Given this list of marker genes Snrpb, Prpf4, Rpl37, Isg20l2, Dcp2, Gemin2, Cdk7, Prpf19, Apobec4, Psmd3, Csnk1e, Cactin, Lsm2, Skic3, Psmb1, Smg7, Rpl36, Rbm42, Hbs1l, Senp3, Zfp36l1, Rps3, Tnfsf13 (tumor necrosis factor (ligand) superfamily, member 13), Psmb3, Tcerg1 (NCBI Gene Id 76839), Psmb2, Pnn, Ptbp1 (NCBI Gene Id 19205), Exosc2, Rpl35rt, Edc4, Prpf40a (pre-mRNA processing factor 40A), Nup58 (NCBI Gene Id 71844), Tra2b, Upf2, Mettl14, Srsf8, Fau, C1d, Lsm1, Rps15a, Puf60, Rbm25, Zc3h18, Slbp, Utp15, Ik, Eif4a2, Prpf31, Pabpn1, Xrn1, Rbmx2, Pelp1, Snu13, Rps19, Polr2h, Ppp2ca, Rpl3, Sec13, Rbm8a, Eri1, Psma4, Cnot10, Sf3b4, Polr2k, Exosc1, Akt1, Rpl29, Cnot2, Rpl32, Bud31, Snrnp70, Nup85, Mettl3, Nup50, Utp4, Hnrnpk, Nxf1, Ppihl, Uba52rt, Htatsf1, Snip1, Nup205, Ubl5, Rps10, Hspa1a, Polr2g, Rplp0, Gtf2f2, Sarnp, Rps5, Rrp36, Ppil2, Cstf2t, Wdr70, Dhx15, Ythdc2, Las1l, Tex10, Ddx42, Nup88, Rbmx, Rpl12, Rps4x, Ebna1bp2, Gemin4, Rps27rt, Sf3a3, Sf3b1, Psma6, Psmd12, Dcaf13, Snrnp25, Nob1, Imp3, Acin1, Snrnp48, Rbm26, Ubc, Rpl36a-ps1, Isy1, Tgs1, Zcchc8, Paip1, Hnrnpa1, Utp14a, Rpl13a, Wdr33 (WD repeat domain 33), Rpl36al, Ctnnbl1, Snrpc, Plrg1 (NCBI Gene Id 99527), Rpl36a, Cwc25, Eif4e, Rps14, Psmd7, Rcl1, Prpf8, Exosc10, Rbm27, Luc7l3 (NCBI Gene Id 67684), Riok2, Ndc1, Magoh, Cnot1, Hnrnpa3, Polr2d, Rpp14, Cdc40, Rpl18 (NCBI Gene Id 19899), Hnrnpl, Smg8, Rnmt, Wdr75, Nup155, Rpl27, Ppp2r2a, Srsf3, Smndc1, Sympk, Cnot9, Zc3h3, Fyttd1, Snrpe, Cstf1, Cnot11, Hnrnpr, Lsm4, Tnks1bp1, Tsr1, Clp1, Rpl4, Hnrnph2, Nsrp1, Skic8, Ubb, Srrm2, Wdr82, Smg9, Rpl21 (ribosomal protein L21), Rpl27a, Syf2, U2af2, Adar, Prcc, Heatr1, Dhx35, Ythdc1, Psmc2, Gemin5, Rps15 (NCBI Gene Id 20054), Psmc5, Adrm1, Ranbp2, Gemin7, Prkrip1, Utp25, Dcp1a, Polr2l, Tbl3, Hnrnpc, Rbm17, Chtop, Rps27l, Gtf2h5, Rps27, Rps25, Nxf7, Rpl17, Smg6, Khsrp, Papolg, Rps8, Prpf3, Nip7, Ncbp1 (nuclear cap binding protein subunit 1), Sf3b3, Srsf5, Thoc3, Ywhaz, Seh1l, Srsf10, Rpl10l, Rps3a1, Rpl22, Ddx6, Ppih, Rps26, Gtf2h2, Pabpc1, Wbp4, Exosc6, Psmc4, Cpsf2, Zrsr2, Dcp1b, Rps27a, Rpl13, Polr2e, Rps29, Wdr36, Papola, Bms1, Rps28, Fus, Xpo1, Lsm11, Hspb1, Smg1, Fam32a, Ywhab (tyrosine 3-monooxygenase/tryptophan 5-monooxygenase activation protein, beta polypeptide), Cnot4, Cnot7, Hnrnpf, Lsm3, Cherp, Polr2b, Cstf2, Snrpn, Clns1a, Wdr18, Rps17, Wdr77, Mfap1a (NCBI Gene Id 67532), Edc3, Mapkapk2, Sf3b5, Pcf11, Mnat1, Polr2f, Gtf2f1, Mphosph6, Rpl34, Nop14, Apobec2, Rpl6, Snrpd3, Gspt2, Rpl10, Rpl19, Snrnp27, Dhx16, Eif4a3, Yju2, Mphosph10, Pnrc2, Rpl26, Rbm39, Anp32a, Sf3a1, Ddx47, Rpl39, Cwc27, Thoc7, Tpr, Zfc3h1, Prpf4b, Smu1, Rngtt, Rps24, Rrp7a, Slu7, Pcbp1, Rpl18a, Rpl10-ps3, Wbp11, Rbm10, Rplp1, Lsm8, Gtf2h4, Dis3, Cpsf1 (NCBI Gene Id 94230), Pom121, Fcf1, Pcbp2, Nudt21, Cpsf4, Dhx38, Ltv1, Rpp40, Zc3h4, Prpf18, Zmat2 (zinc finger, matrin type 2), Rpl14, Alyref, Rps16, Hspa8, Sart1, Exosc3, Rpl24, Sugp1, Bcas2, Wtap, Ppil1 (peptidylprolyl isomerase (cyclophilin)-like 1), Psmc1, Patl1, Psmd2, Ncl, Hnrnpu, Lsm7, Cpsf3, Cnot6l, Uba52, Crnkl1, Rpl30, Wdr43, Pan3, Adarb1, Usp39, Rpsa, Psmd11, Nup62, Snrpb2, Pwp2, Gpatch1, Psmb6, Snrpa1, Psmb4, BC005624, Thoc2, Steep1, Nol6, Rps18, Rps2, Sf3b2, Noc4l, Rpl23, Phf5a, Rrp9 (ribosomal RNA processing 9, U3 small nucleolar RNA binding protein), Skic2, Krr1, Emg1, Riok1, Ppil4, Rpl11, Nol11, Pqbp1, Ddx39a, Cpsf7, Exosc8, Ybx1, Rpp21, Cwc22, Bysl, Gtf2h1, Pan2, Gpkow, Rpl23a, Cpsf6, Psmb5, Rplp2, Dhx9, Rpl7a, Rps12, Nup133, Riok3 (NCBI Gene Id 66878), Eif4a1, Nkap, Rps20, Rpl28, Psmc3, Rps13, Gtf2h3, Dhx8, Ddx21, Rps7, Sde2, Gemin6, Snrpg, Mfap1b, Leng1, Rpl35, Set, Psma7, Upf3a, Gnl3, Pno1, Nup35, Nxt1, Gle1, Rpp38, Smn1, Elavl1, Nup107, Wdr46, Xab2, Srrm1, Nup214, Snrnp40, Nup153, Srsf7, Utp3, Snrpd2, Upf1, Psmd8 (NCBI Gene Id 99154), Utp11, Cnot6, Xrn2, Rae1, Pes1, Psmd1, Rnps1, Rpp25, Zmat5, Rpl5, Psmd13, Psma1, Sf1, Rpl37a, Lsm6, Psmd6, Utp20, Supt5 (NCBI Gene Id 20924), Rps23, Nup37, Fip1l1, Rpl35a (ribosomal protein L35A), Prpf6 (NCBI Gene Id 75696), Ddx23, Zfp36, Rpl3l, U2surp, Eftud2, U2af1, Apobec1, Nup42, Snupn, Ercc3, Snrpf, Hspa1b, Wdr3, Utp14b, Prkcd, Ppil3, Nol9, A1cf, Nup54, Wdr12, Exosc4, Etf1, Psma3, Ccnh, Mtrex, Cnot3, Dcps, Ddx52 (NCBI Gene Id 78394), Snrnp200, Ddx49, Cnot8, Ddx20, Bop1 (block of proliferation 1), Hnrnpd, Fam50a, Nup188, Psmb7, Fbl, Gm6525, Zfp473, Utp6, Apobec3, Hnrnph1, Snrnp35, Nop56, Nxf2, Aaas, Srsf11, Prpf38a, Rpl15, Rnf113a1, Psmd14, Nup93, Rbm5, Psmc6, Thoc1, Nup160 (NCBI Gene Id 99202), Ddx41, Prmt5, Rbm22, Rpl39l, Rpl31, Srsf1, Pdcd11, Txnl4a, U2af1l4, Gemin8, Srsf9, Psma5, Cdc5l, Ppwd1, Imp4, Poldip3, Utp18, Eif4g1, Cwc15, Rpl7, Srsf2, Gspt1 (NCBI Gene Id 98017), Exosc7, Csnk1d, Rps11, Ncbp2, Ddx5, Eif4b, Rps6 (NCBI Gene Id 20104), Smg5, Casc3, Hnrnpa2b1, Upf3b, Aqr, Rps9, Rbm7, Srrt, Lsm5, Polr2a, Thoc6, Nup210, Tnpo1, Rpl22l1, Bud13, Psma2, Lsm10, Snrpa, Zcrb1, Ccdc12, Rnpc3, Rpl38, Rpl9, Rps21, Pdcd7, Parn, Ercc2, Rpp30, Polr2i, Cstf3, Bud23, Ddx39b, Nt5c3b, Dhx37, Snrpd1, Ftsj3 (FtsJ RNA 2'-O-methyltransferase 3), Polr2c, Rpl8, Zfp830, Zc3h11a, Nup43, Nop58, Sf3a2, Ddx46, Exosc5, Exosc9, Ppp2r1a, Nup98, here is a description of the gene set: Mouse Gene Set: REACTOME_METABOLISM_OF_RNA species: Mus musculus Metabolism of RNA